Given this list of marker genes RB1, E2F3, E2F1, CCNE2, CDKN2A, TP53, CCNE1, E2F2, CDKN1A, MDM2, CDK2, here is a description of the gene set: Human Gene Set: KEGG_MEDICUS_REFERENCE_MDM2_P21_CELL_CYCLE_G1_S_N00536 species: Homo sapiens Pathway Definition from KEGG: CDKN2A -| MDM2 -| TP53 => CDKN1A -| (CCNE+CDK2) -> RB1 // E2F MDM2-p21-Cell cycle G1/S. Pathway ID: N00536. Pathway type: Reference. Pathway class: nt06263 Hepatocellular carcinoma.